The following is a description of a gene set: Reactome Pathway: The NLRP1 inflammasome This event has been computationally inferred from an event that has been demonstrated in another species.<p>The inference is based on the homology mapping from PANTHER. Briefly, reactions for which all involved PhysicalEntities (in input, output and catalyst) have a mapped orthologue/paralogue (for complexes at least 75% of components must have a mapping) are inferred to the other species. part of: Inflammasomes electronically inferred by orthology from the curated human pathway studied in species Mus musculus, and this is the list of marker genes: Bcl2l1